Given this list of marker genes NDEL1, MMP10, BMP1, KRT80, GPR68, KRT5, LRRC8E, GIPC1, GLIPR1, JPT1, PPARD, ILVBL, TINF2, CT69, SLC35F6, CD44, ADAM12, KCTD11, CDSN, OVOL1 (NCBI Gene Id 5017), HBEGF, TOM1, VAMP3, ITPRID2, FAT2, LRRC8C, P4HA2, SDC1, NR1D1, C4orf3, CASP4, GNA15, OSTM1, YIPF5, GOLGA5, ARRDC4, KLC1, ASPRV1, USB1, TANGO6, TRIM7, TUBA4A, KRT6B, BICD2, SLC7A5, RAB10, AHNAK, ARL4D, CEMIP, NT5E, IPPK, HTRA1, WASL, NGEF, ZBED2, CWH43, KLK8, SLC39A3, KLK7, PLS3, CERS3, B3GNT9, ADCY7, HYCC1, ALAS1, PHACTR2, ZNF750, N4BP1, MSRB1, VLDLR, MAST4, ERAP2, REEP5, PCSK7, SPRR4, AP3S1, ZC3HAV1, PIP4K2C, ADGRF4, PAM, KLF10, ARL8B, DLGAP4, SPTLC1, SERINC2, TMEM40, GM2A, KRT14, ALS2CL, YIPF2, MAN2A1, ELL2, TMEM154, GSKIP, SLAMF9, MYD88, ENSG00000254531, MTF1, MFAP3, MXD1, IGFL1 (NCBI Gene Id 374918), GPM6B, DUSP14, GALNT10, C1orf116, TPM4, CCL24, TTLL11, MTPN, CARD10, BNC1, PTBP3, IL36RN, ABHD6, NABP1, ADAMTS15, CDC37L1, C1QTNF6, MICALL1, KLK10, TNS4, MAPK6, DHRS7, CPEB4, CDKN1A, NRBF2, SLC9A1, RAB31, KLHL18, FAM131B-AS2, BAK1, KLK11, SLC27A4, CAVIN1, SDR9C7, ADAMTS14, TRIP11, LUZP1, FKBP14, YKT6, IGFL2, FAXDC2, DCBLD1, PGGT1B, CRYBG2, KDELR3, TES, ABCA12, TMSB10 (NCBI Gene Id 9168), ADM, SAR1B (NCBI Gene Id 56680), PPP2R5B, FKBP15, CISH, USP15, IGFBP6, IVL, KCNK6, FABP5, RAB38, EHD1, MAFB, KCTD10 (potassium channel tetramerization domain containing 10), WDR83OS, PCDH7, NUP50, LIMA1, KCTD5, TCP11L1, INPP4B, ABHD5, SH3BGRL3, IL13RA1, CPM, ARHGEF37, BACH1, TUBB6, PLEKHM1, DAPK3, TRAPPC3, GDPD2, AP1M2, KLF6, HMOX2, SBDS, LPAR5, TMCC3, DUSP7, TNFAIP1, JUP, AHNAK2, S100A6, SMTN, UBAP1, GOLT1B, MAP7D1, KCNK10, CARD6, MCOLN1, HES2, ENSG00000291149, SAR1A, KRT16, MCUB (mitochondrial calcium uniporter dominant negative subunit beta), FST, OCEL1, BSG, EHBP1L1, R3HDM4, DDA1, PLIN3, DSP, HRH1 (NCBI Gene Id 3269), PRDM1, FAM114A2, ATL3, IL1A, KRT17 (keratin 17), PDPN, HOMER3, MYO5A, PRR9, OXSR1, NUMB (NUMB endocytic adaptor protein), LINC02762, MRC1, IL20RB, NRG1, CLIP1, STRN3, NECTIN4, LTB4R, NACC1, COL5A3, ZDHHC3 (NCBI Gene Id 57245), LDHA, CC2D1B, KLC3, LRFN4, GNAI1, SLC30A4 (NCBI Gene Id 7782), ERO1A, SPRR1B, EGLN3, PPP1R1C, RAB8A, DCUN1D3, CD36, METRNL, RAB3D, SLC2A1, TP63, LCE3D, ANKRD9, ANKRD13A, FAM83A, IMPDH1, RNASE7, PCYT1A, IFFO2, CCDC85C, GJB2, GJB6, AFAP1L1, CALM1, FRMD6, TREM1, MMP1, RNF39, STK17A, UBE2Q2, LRRC59, PLEKHB2, MAP4, SQOR, RARS1, ATP6V0D1, SEMA4B, STON2, MRPL4, SHFL, ITPRIP, COCH, CORO1C, TSPAN5, HERC4, C6orf132, ORMDL2, GOLGA7B, STARD5, ARF4, STX12, EHD2, TMEM79, SYNPO, FBXO8, RIC1, SGMS2, ELOF1, INHBA, LRRFIP1, SLC44A1, UPP1 (NCBI Gene Id 7378), PTGFRN, LPCAT2, PSMD12, NIPAL4, UBE2A, TANC2, EPPK1, TEX2 (testis expressed 2), NUP50-DT, EREG, SLC31A1, PTHLH, DESI1, SLC31A2, PNP, CARHSP1, MAPK1, FEM1C, MAFK (NCBI Gene Id 7975), PTGS1, CDC37, CLCA2, CA12, TWF1, HIF1A, AGPAT4, PERP, DNAJB5, TICAM1, MEAK7, GPR157, HSD17B1, NPEPPS, KRT6A, S100A2, UBE2L3, DOCK6, SDCBP2, TXNDC17, GAS2L1 (NCBI Gene Id 10634), FHIP1A, SFN, TTC39B, HPSE, DSC1, FBLIM1, CSNK1E, RHOV, PLAUR, ULBP2, PDCD6IP, DUOXA1, SMIM12, MKNK1, PPIC, PSD4, S100A8, LINC00520, CSNK1A1, KLF7, MTRF1L, PLBD2, SNX33, OSBPL10, ZDHHC5, EVI5L, SNRK (SNF related kinase), GSDMC, ATP6V0E1, BZW1, NLRX1, PXN, RCAN1, DYNLL1, SLC38A7, CFAP251, CDCP1, GRHL3, CNGB1, SH3PXD2B, ELMOD2, here is a description of the gene set: from publication Rickman DS, Millon R, De Reynies A, Thomas E, Wasylyk C, Muller D, Abecassis J, Wasylyk B (PMID 18679425) Propensity for subsequent distant metastasis in head and neck squamous-cell carcinoma (HNSCC) was analysed using 186 primary tumours from patients initially treated by surgery that developed (M) or did not develop (NM) metastases as the first recurrent event. Transcriptome (Affymetrix HGU133_Plus2, QRT-PCR) and array-comparative genomic hybridization data were collected. Non-supervised hierarchical clustering based on Affymetrix data distinguished tumours differing in pathological differentiation, and identified associated functional changes. Propensity for metastasis was not associated with these subgroups. Using QRT-PCR data we identified a four-gene model (PSMD10, HSD17B12, FLOT2 and KRT17) that predicts M/NM status with 77% success in a separate 79-sample validation group of HNSCC samples. This prediction is independent of clinical criteria (age, lymph node status, stage, differentiation and localization). The most significantly altered transcripts in M versus NM were significantly associated to metastasis-related functions, including adhesion, mobility and cell survival. Several genomic modifications were significantly associated with M/NM status (most notably gains at 4q11-22 and Xq12-28; losses at 11q14-24 and 17q11 losses) and partly linked to transcription modifications. This work yields a basis for the development of prognostic molecular signatures, markers and therapeutic targets for HNSCC metastasis. Human Gene Set: RICKMAN_TUMOR_DIFFERENTIATED_WELL_VS_POORLY_DN Down-regulated genes that vary between HNSCC (head and neck squamous cell carcinoma) groups formed on the basis of their level of pathological differentiation: well vs poorly differentiated tumors. species: Homo sapiens